The following is a description of a gene set: Human Gene Set: E2F1_Q6 studied in species Homo sapiens Genes having at least one occurrence of the motif TTTSGCGS in the regions spanning 4 kb centered on their transcription starting sites. This matches the E2F1 transcription factor binding site V$E2F1_Q6 (v7.4 TRANSFAC)., and this is the list of marker genes: OTUD7B, PHF13, MAZ, ASXL2, PRKDC, RMI2, SLC9A5, IL4I1, PRPS2, ZNF644, KBTBD6, SMC6, MCMBP, PAQR4, GMNN, PAX6, RANBP1, SUV39H1, ID3, EPHB1, STT3B, E2F1, SUMO1, SP3, ERBIN, TOPBP1, ZCWPW1, SALL1, MCM7, HMGA1, UGGT1, NELL2, DMD, CDK1, SPTB, NCL, GAPDH, SPINK5, NUFIP2, SYNCRIP, KLF5, MYC, MAP3K7, RPS6KA5, FIZ1, ZNF524 (zinc finger protein 524), ALDH6A1, PCNA, DCTPP1, GINS3, FLI1, TRMT13, MCM6, PHF5A, SMC1A, SERBP1, NASP, RRM2, GSPT1, CDC6, RPS20, CLSPN, PRPS1, ARID4A, HIRA, RBBP4, FMO4, TYRO3, POLE4, PAN2, CDT1, ZNF362, HNRNPD, SASS6, HS6ST3, H2AZ1, RIBC1, MCM8, ING3, IER5L, CTDSPL2, CDC25A, FKBP5, ZNF687, PKMYT1, FANCD2, LUC7L3, GPRC5B, PCLAF, AK2, CBX3, POLE2, RAVER1, TMEM143, DNAJC9, NUP62, YBX2, SRSF1 (serine and arginine rich splicing factor 1), MSH5, E2F3, EFNA5, USP37, NABP2, E2F8, EED, FANCG, PPM1D, POLR2A, CDCA7, NECTIN1, ZNF565, RBL1, IPO7, GRIA4, STMN1, UNG, CDC5L, FANCC, NIPBL, NOLC1, H4C1, MYH10, GPN3, ZBTB4, ZCCHC8, CCNT1, ATF5, GABRB3, NFATC2IP, TMPO, SMAD6, THAP8, AP1S1, TBX6, DNMT1, HNRNPA2B1, SLCO3A1, EZH2, STK35, NRK, ACBD6, SMC3, SSBP3, POLA1, PBRM1, HNRNPR, HNRNPUL1, HCN3, SNRPD1, EHBP1, POLD1, SLC25A3, ATAD2, CAND1, HMGXB4, MCM2, ATAD5, GEN1, APH1A, H3C1, VCAN, MTF2, TRMT2A, APPL1, ZBTB8OS, EMSY, JADE1, ORC1, CTCF, TFAP4, PRP4K, ILF3-DT, SOAT1, MCM3, POLR1G, BRMS1L, CACNA1G, H2AZ2, SYNGR4, EMC3, TRA2B, STAG2, ADAMTS2, KBTBD7, PODN, BRME1, DNAJC5G, SEMA6A (NCBI Gene Id 57556), KCNA6, PRPF38A, SLC9A7, MEPCE, SRSF7, KPNB1, CTNND2, PHC1, E2F7, HOXC10, POLD3, TAOK2, YTHDC1, TMEM108, SREK1, MSH2, ILF3, KIAA0825, CORT, CNOT9, FHOD1, TMEM187, AP4M1, KCNS2, MCM4, PCSK1, RASAL2, DCK, ARHGAP6, STAG1, ACO2, CASP8AP2, UBR7, JADE2, FBXO5, GON7, ATE1, H2BC12, TRMT6, GATA1, ZNF367 (NCBI Gene Id 195828), PIM1, ARHGAP11A, MXD3, WDR62, MRPL40, FAM216A, H2AC12